Given this list of marker genes DAZAP2, DNAJB2, SLC12A4, XIAP, FERMT2, MCRS1, AXIN1, IRF5, CAB39, NAIP, BACE1, STING1, MAPK8, MAPRE3, CDC6, APP, CDKN1A, MAPRE1, CCDC102B, PRKCH, PYDC1, MAP3K7, MAVS, CDC25C, VHL, here is a description of the gene set: Human Gene Set: GOMF_PROTEIN_SERINE_THREONINE_KINASE_BINDING Binding to a protein serine/threonine kinase. studied in species Homo sapiens